The following is a description of a gene set: species: Homo sapiens The aggregation, arrangement and bonding together of proteins and RNA molecules to form a stress granule. Human Gene Set: GOBP_STRESS_GRANULE_ASSEMBLY, and this is the list of marker genes: CSDE1, DAZAP2, ATXN2, ATG5, FMR1, DDX6, EIF2S1, LSM14A, OGFOD1, BICD1, MAPT, DDX3X, CIRBP, GRB7, ANG, HSF1, YTHDF3, PRRC2C, YTHDF2, PUM2, DYNC1H1, YTHDF1, ATXN2L, BECN1, PRKAA1, UBAP2L (ubiquitin associated protein 2 like), RPS23, USP10, TIA1, PRKAA2, C9orf72, G3BP1, STYXL1, CAPRIN1, G3BP2